The following is a description of a gene set: Acetylcholine regulates insulin secretion studied in species Mus musculus Mouse Gene Set: REACTOME_ACETYLCHOLINE_REGULATES_INSULIN_SECRETION, and this is the list of marker genes: Plcb3, Gna15, Plcb1, Plcb2, Gnaq, Gna11, Marcks, Gna14